Given this list of marker genes Rasgrp1, Il12a, Il12b, Rhbdd3, Zfp683, Gas6, Ulbp1, Il23a, Havcr2, Slamf7, Tox, Dcaf15, Tyk2, Hps1, Klrd1, Stat5b, Pglyrp1, Pglyrp4, Irf1, Pglyrp3, Clec12a, Fgr, Sh2d1b2, Mill1, Pglyrp2, Il21, Il15ra, Lgals9, Ticam1, Bloc1s6, Lilrb4a, Lyst, Ptpn22, Flt3l, Pibf1, Lep, Il18, H2-T23, Bloc1s3, Axl, Prdm1, Raet1d, Il15, Jak2, Zbtb1, Clnk (NCBI Gene Id 27278), Tyrobp, Stat5a, Cd244a, here is a description of the gene set: Mouse Gene Set: GOBP_REGULATION_OF_NATURAL_KILLER_CELL_ACTIVATION Any process that modulates the frequency, rate or extent of natural killer cell activation. species: Mus musculus